The following is a description of a gene set: To investigate the molecules that regulate the acquisition of cis-diamminedichloroplatinum (II) (cisplatin) resistance, we performed cDNA microarrays using two pairs of parental and cisplatin-resistant bladder cancer cell lines. We found a markedly reduced expression of inositol 1,4,5-trisphosphate (IP3) receptor type1 (IP3R1), endoplasmic reticulum membrane protein, in cisplatin-resistant cells. The suppression of IP3R1 expression using small interfering RNA in parental cells prevented apoptosis and resulted in decreased sensitivity to cisplatin. Contrarily, overexpression of IP3R1 in resistant cells induced apoptosis and increased sensitivity to cisplatin. These results suggest that cisplatin-induced downregulation of IP3R1 expression was closely associated with the acquisition of cisplatin resistance in bladder cancer cells. species: Homo sapiens from publication Tsunoda T, Koga H, Yokomizo A, Tatsugami K, Eto M, Inokuchi J, Hirata A, Masuda K, Okumura K, Naito S (PMID 15608674) Genes down-regulated in bladder cancer cells resistant to cisplatin compared to the parental cells sensitive to the drug. Human Gene Set: TSUNODA_CISPLATIN_RESISTANCE_DN, and this is the list of marker genes: FSTL3, CFB, ANXA8L1, ITPR1, S100P, C1S, SLC27A2, FBN2, TCIM, PTGS2, KYNU, CPS1, STK26, ELL2, CASP9, C4BPB, PRMT3, HLA-DRB3, ID1, RABEPK, WNT5A, FBN1, CD74, CTSB, EPAS1, LCMT2, NPR3, ESRP2, PTGES, C3, PDE3A, SLC7A5, MAGEA9, FOLR3, FOLR1, IGFBP4, MAGEA6, B4GALT1, KRT7, ASS1, SLC3A2 (NCBI Gene Id 6520), HLA-DPA1, SGK1, CLU, TSC22D1, FOLR2, FN1, SORD, GALNT2, CRIP1